Given this list of marker genes BUB1B, TOP2A (NCBI Gene Id 7153), FLT4, CREM, DMTN, SMC4, HMGB2, TK1, SMAGP, CDKN1C, DSP, GINS1, GPRC5B, PEG10, CCNE2, MYBL2, CSRP2, MCM6, CDK1, BTBD3, PDLIM3 (NCBI Gene Id 27295), CH25H, NDC80, GCH1, UBE2C, here is a description of the gene set: Lymphatic vessels are essential for fluid homeostasis, immune surveillance and fat adsorption, and also serve as a major route for tumor metastasis in many types of cancer. We found that isolated human primary lymphatic and blood vascular endothelial cells (LECs and BECs, respectively) show interesting differences in gene expression relevant for their distinct functions in vivo. Although these phenotypes are stable in vitro and in vivo, overexpression of the homeobox transcription factor Prox-1 in the BECs was capable of inducing LEC-specific gene transcription in the BECs, and, surprisingly, Prox-1 suppressed the expression of approximately 40% of the BEC-specific genes. Prox-1 did not have global effects on the expression of LEC-specific genes in other cell types, except that it up-regulated cyclin E1 and E2 mRNAs and activated the cyclin e promoter in various cell types. These data suggest that Prox-1 acts as a cell proliferation inducer and a fate determination factor for the LECs. Furthermore, the data provide insights into the phenotypic diversity of endothelial cells and into the possibility of transcriptional reprogramming of differentiated endothelial cells. Human Gene Set: PETROVA_PROX1_TARGETS_UP species: Homo sapiens from publication Petrova TV, Mäkinen T, Mäkelä TP, Saarela J, Virtanen I, Ferrell RE, Finegold DN, Kerjaschki D, Ylä-Herttuala S, Alitalo K (PMID 12198161) Genes specific to LEC (lymphatic endothelium cells) induced in BEC (blood endothelium cells) by expression of PROX1 off adenovirus vector.